The following is a description of a gene set: Human Gene Set: GOBP_TISSUE_HOMEOSTASIS studied in species Homo sapiens A homeostatic process involved in the maintenance of an internal steady state within a defined tissue of an organism, including control of cellular proliferation and death and control of metabolic function., and this is the list of marker genes: STK39, BBS2, MUC2, SPATA7, SNX10, AIPL1, SASH3, HTR4, RP1L1, PTH1R (parathyroid hormone 1 receptor), SCX, TNFRSF11A, MKS1, NXNL2, RAC1 (NCBI Gene Id 5879), XIAP, CDH3, TJP3, KLHL10, FSHB, GJA1, ILDR1, CTNNB1 (catenin beta 1), GATA2, MC4R, DRAM2, BBS10, CD38, RBP4, FH, IL20RB, DEF8, PBLD, IAPP, RPE65 (retinoid isomerohydrolase RPE65), SERPINA3, S1PR1, LACRT, F11R, NDP, ERRFI1, BAP1, MUC13, ABCC8, PTPN11, MKKS, GPR55, ITGB3, ABCB1, FOXC1, SLC2A1, CLDN3, CD34, SRF, TUB, LAMC1, EXT1, TLR4, SRC, TNFAIP3, ZNF675, CRACD, LDB1, BBLN, ABCA4, PRDX5, SLC28A2, NPHP3, SOX9, GATA1, CSK, NT5E, NOS3, CLDN5, SCRIB, ADAM8, CYTL1, PRICKLE1, VSIG1, CLRN1, ANGPT1, TMEM64, CHMP4B, PROM1, JAM2, WHRN, LSR, IL7, GPR137B (G protein-coupled receptor 137B), MIR204, ILDR2, GIGYF2, AKT3, LTBP3, TJP2, NXNL1, USH1G, RPA1, CARTPT, KMT2A, TULP1, ANKH, CLDN12, PRKCA, GJB6, IL20RA, CCDC66, P2RX4, LIPA, CLN8, F2R, TRIM32, PCDH15, ACP5, PERP, TUBA1A, WNK3, STK11, SMO, TPP1 (tripeptidyl peptidase 1), RAB3D, CLCN3 (NCBI Gene Id 133073), CLDN18, CSF1R, ACACA, CSF1, BBS4, TRAF6, MIP, ERCC6, MINAR2, VSTM4, EPG5, TFF3, CD2AP, ITGB1, SLC12A2, SLC4A2, NR1I2, POC1B, CIB2, SYK, NOX4, PRDM14, IQCB1, PKP3, RAC3, CDH5, VPS13B, TNFSF11 (TNF superfamily member 11), NOD2, HOXA13, ALDH1A1, JAM3, MBP, RAC2, SPP1, TCIRG1, MAK, INAVA, TJP1, MFSD2A, CRB1, MTF1, NCDN, BBS1, CROCC, MUC6, SH3GL2, COL3A1, RB1 (RB transcriptional corepressor 1, NCBI Gene Id 92728), RAB7A, CLDN1, PECAM1, TFF1, SLC1A1, NFKBIZ, CALCA (calcitonin related polypeptide alpha), NOTCH1, ABCC6, ELP6, BARD1, NPHP4, P2RX7, CDHR1, ADRB2, ZEB2, VEGFA, FOSL2, COL2A1, SLC22A5, SOD1, IL6, WWTR1, IHH (NCBI Gene Id 50819), GPR137, SIGLEC15, NEUROD1, TP53INP2, USH2A, IL10RA, TFF2, INPP5D, VPS54, CORO1A, CTSK, CNGB1, PRLH, CDH23, ARAP1, PRRC1, PLEKHM1, OCLN, IFT80, YAP1, DCSTAMP, GCNT2, ASCL3, BAX, BRINP1, NFIB, DMD, STRAP, ACTG1, APBB2, GNAT2 (NCBI Gene Id 92084), ADGRV1, PDK4, CUBN, PIWIL4, BBS12, SLC39A8, CXADR, RP1, LCA5, BSG, COMP, NANOS1, VCL, CCN2, ESRRB, RHO, USP45, NF1, TMEM119, KRAS, CCR2, ARMS2, UBASH3B, RUFY4, LAMA2, ESAM, ATP1B2 (NCBI Gene Id 482), BCL2, PTK2B, IL17A, ALPL, BGLAP, KCNJ1, ZNF830, RDH12, FSHR, ACTB, PTH, USH1C, NAGLU, COL14A1 (collagen type XIV alpha 1 chain), MUC4, CRB2, TSPAN12, TLR9, LRRK1 (NCBI Gene Id 79705), LDB2